Given this list of marker genes BIRC3, LCN2, MAP3K8, CSF1, C19orf48P, IRF1, MDM2, TNIP1, BTG2, DUSP6, RELB, NFKB2, DUSP16, NFKBIA (NCBI Gene Id 4792), TNFAIP3, NFKBIB, IFNGR2, CXCL2, here is a description of the gene set: Human Gene Set: RASHI_NFKB1_TARGETS Known and putative targets of NFKB1 identified among the ATM dependent, late responders to ionizing radiation. The ATM protein kinase, functionally missing in patients with the human genetic disorder ataxia-telangiectasia, is a master regulator of the cellular network induced by DNA double-strand breaks. The ATM gene is also frequently mutated in sporadic cancers of lymphoid origin. Here, we applied a functional genomics approach that combined gene expression profiling and computational promoter analysis to obtain global dissection of the transcriptional response to ionizing radiation in murine lymphoid tissue. Cluster analysis revealed a prominent pattern characterizing dozens of genes whose response to irradiation was Atm-dependent. Computational analysis identified significant enrichment of the binding site signatures of NF-kappaB and p53 among promoters of these genes, pointing to the major role of these two transcription factors in mediating the Atm-dependent transcriptional response in the irradiated lymphoid tissue. Examination of the response showed that pro- and antiapoptotic signals were simultaneously induced, with the proapoptotic pathway mediated by p53 targets, and the prosurvival pathway by NF-kappaB targets. These findings further elucidate the molecular network induced by IR, point to novel putative NF-kappaB targets, and suggest a mechanistic model for cellular balancing between pro- and antiapoptotic signals induced by IR in lymphoid tissues, which has implications for cancer management. The emerging model suggests that restoring the p53-mediated apoptotic arm while blocking the NF-kappaB-mediated prosurvival arm could effectively increase the radiosensitivity of lymphoid tumors. studied in species Mus musculus from publication Rashi-Elkeles S, Elkon R, Weizman N, Linhart C, Amariglio N, Sternberg G, Rechavi G, Barzilai A, Shamir R, Shiloh Y (PMID 16314843)